The following is a description of a gene set: species: Homo sapiens Human Gene Set: REACTOME_XENOBIOTICS Xenobiotics, and this is the list of marker genes: ARNT, CYP3A43, CYP2E1, CYP2D6, CYP2W1 (NCBI Gene Id 54905), AHR, CYP1A1, CYP2F1, CYP2B6, CYP3A7, CYP2C9, CYP2J2, CYP2A13, CYP3A4, CYP2C8, CYP2A7, CYP3A5, CYP2S1, CYP2C19 (cytochrome P450 family 2 subfamily C member 19), CYP1A2, CYP2A6, ARNT2, CYP2C18